The following is a description of a gene set: Cerebellar calcifications Human Gene Set: HP_CEREBELLAR_CALCIFICATIONS studied in species Homo sapiens, and this is the list of marker genes: PDGFRB (platelet derived growth factor receptor beta), CMPK2, SNORD118, JAM2, NAA60, ERCC8, RBBP8, ERCC6, MYORG, TREX1, SLC20A2, PDGFB